Given this list of marker genes Kcnq1, Kcne3 (NCBI Gene Id 80572), Akap9, Kcne2, Kcne4, Kcne5, Kcna5, Kcnh2, here is a description of the gene set: Mouse Gene Set: REACTOME_PHASE_3_RAPID_REPOLARISATION studied in species Mus musculus Phase 3 - rapid repolarisation